The following is a description of a gene set: A large complex that acts as a tethering factor involved in transporting vesicles from the ER through the Golgi to the plasma membrane. A TRAPP (transport protein particle) complex has a core set of proteins which are joined by specific subunits depending on the cellular component where a given TRAPP complex is active. species: Homo sapiens Human Gene Set: GOCC_TRAPP_COMPLEX, and this is the list of marker genes: TRAPPC8, TRAPPC3, TRAPPC2, TRAPPC9, TRAPPC10, TRAPPC2L, TRAPPC3L, TRAPPC1, TRAPPC5, TRAPPC12, TRAPPC6A (trafficking protein particle complex subunit 6A), TRAPPC14, TRAPPC11, TRAPPC6B, TRAPPC4, TRAPPC2B, TRAPPC13